Given this list of marker genes Abcg8, Trnp1, Ghitm, Gars1, Dip2a, Asph, Reln, Wwtr1 (WW domain containing transcription regulator 1), Eps15l1, Epg5, Msln, Grm3, Gabra4, Gpatch11, Myh15, Tsr2, L3mbtl4, E2f4, Tnfrsf21 (NCBI Gene Id 98092), Vgll3, Akirin2, Tex9, Rab8b, Map1b, Agbl5, Cggbp1, Ddx3x, Tnrc6a, Fchsd2, Ttc7b, Itpripl2, Asb11, Wnk2, Rab2a, Kcnk10, Kdm4c, Slc8a1, Klc1, Odf2, Rd3l, Slc2a13, Uri1, Prkg1, Pgs1, Fhit, Gabra6, Rab9b, Fhip1b, Efnb3, Prtg, Serpinb8, Tirap, Or13e8, Snx22, Slc25a5, Khdc4, Esyt1, Pdcd10, Sh2b2, Ptbp3, Tspyl5, Usp49, Lrp3, Gm11545, Gid4, Man1a2, Aff3, Spin4, Pkn2, Mob3a, Fndc3a, Zfp182, here is a description of the gene set: Mouse Gene Set: MIR_210_5P from publication Chen Y, Wang X (PMID 31504780) studied in species Mus musculus Genes predicted to be targets of miRBase v22 microRNA mmu_miR_210_5p in miRDB v6.0 with MirTarget v4 prediction scores > 80 (high confidence targets).